The following is a description of a gene set: studied in species Homo sapiens Any process that modulates the frequency, rate or extent of the controlled release of an icosanoid from a cell. Human Gene Set: GOBP_REGULATION_OF_ICOSANOID_SECRETION, and this is the list of marker genes: SYK, OXT, P2RX7, TNFRSF11A, CYP4F2, NTSR1, TNFSF11, CYP4A11, ACSL4, EDN1, PLA2G10, AVPR1B, PLA2R1, P2RX4, PTGES, MIF, IL1B, PLA2G4A, PLA2G3